Given this list of marker genes PELI3, BCL2, ITGAV, ACVR1, CTNNA1, NOS3, MIR222, PSME3, PRDX2, SIAH2, IL19, EYA1, IFI6, UNC5B, SNAI2, BIRC6, STRADB, EYA3 (NCBI Gene Id 2140), LMNA, GCLC, KLF4, ZMYND11, HTT, EYA2, MIR221, HSPA1A, PF4, FAIM2, CSF2, YAP1, AKT1, RELA, TNF, GRINA (NCBI Gene Id 2907), FYN, ITGA6, TGFBR1 (transforming growth factor beta receptor 1), SCG2, HSPA1B, NRP1, TNFAIP3, SFRP2, CX3CL1, BRCA1, TERT, BMP5, FGA (fibrinogen alpha chain), PAK5, ARHGEF2, BCL2L1, IL1A, MAP2K5, GCLM, IGF1, SH3RF1, NOL3, ITPRIP, MAPK7, SERPINE1, SGK3, GDNF, FGG, PHIP, MIR142, HMOX1, ICAM1, MIR199A1, DDX3X, GPX1, RNF34, C8orf44-SGK3, TMBIM1, FAIM, GATA1, RB1CC1 (NCBI Gene Id 9821), IL1B, HGF, BMP4, FGB, GSK3B, RAF1, PARK7, EYA4, COL2A1, CTTN, LGALS3, TCF7L2, THBS1, RPS6KB1, RFFL, SRC, IL7, MCL1, PEA15, GSTP1, SCRT2, AR, GFRAL, NRG1, RIPK1, HMGB2, CFLAR (CASP8 and FADD like apoptosis regulator), FGF10, here is a description of the gene set: species: Homo sapiens Human Gene Set: GOBP_NEGATIVE_REGULATION_OF_EXTRINSIC_APOPTOTIC_SIGNALING_PATHWAY Any process that stops, prevents or reduces the frequency, rate or extent of extrinsic apoptotic signaling pathway.